The following is a description of a gene set: Human Gene Set: GOBP_APICAL_PROTEIN_LOCALIZATION Any process in which a protein is transported to, or maintained in, apical regions of the cell. studied in species Homo sapiens, and this is the list of marker genes: JAM3, MAL (NCBI Gene Id 4118), VANGL2, GOPC, CELSR1, HCN1, RDX, NAPA, ATP8B1, DLG5, ACTB (NCBI Gene Id 60), SHROOM2, SHROOM3, ARF4, INSC, NCKAP1